The following is a description of a gene set: Human Gene Set: REACTOME_INTERLEUKIN_21_SIGNALING Interleukin-21 signaling species: Homo sapiens, and this is the list of marker genes: STAT5B, IL2RG, JAK1, STAT5A, IL21, IL21R, STAT4, JAK3, STAT1, STAT3